Given this list of marker genes GTF2H2C, GTF2H2C_2, GTF2H5, CCNT1, SNW1, GTF2H4, MMS19, CCNH, CCNT2, GTF2H3, CCNK, RB1, CDK9 (cyclin dependent kinase 9), ERCC2, ERCC3, CDK7, CDK12, CDK13, GTF2H1, GTF2H2, MNAT1, here is a description of the gene set: A protein complex that phosphorylates amino acid residues of RNA polymerase II C-terminal domain repeats; phosphorylation occurs mainly on Ser2 and Ser5. Human Gene Set: GOCC_CARBOXY_TERMINAL_DOMAIN_PROTEIN_KINASE_COMPLEX species: Homo sapiens